Given this list of marker genes Plppr3, Plpp2, Plppr5, Plppr1, Plppr2, Plpp5, Lpin2 (lipin 2), Plppr4, Plpp1, Plpp6, Lpin3, Lpin1, Plpp4, Plpp3, here is a description of the gene set: studied in species Mus musculus Catalysis of the reaction: a 1,2-diacylglycerol 3-phosphate + H2O = a 1,2-diacyl-sn-glycerol + phosphate. Mouse Gene Set: GOMF_PHOSPHATIDATE_PHOSPHATASE_ACTIVITY